Given this list of marker genes PTTG2, C14orf39, TERB2, EHMT2 (euchromatic histone lysine methyltransferase 2), ESPL1, MEIKIN, MND1 (NCBI Gene Id 84057), CENPC, MLH3, MAEL, MLH1, TEX11, MAJIN, CCNB1IP1, SYCE1, SHOC1, SPDYA, RNF212, SPATA22, SYCP2, PTTG1, MSH5, TERF1 (NCBI Gene Id 7013), REC8, MEIOB, HORMAD1, CCNE1, SYCE2, TRIP13, MSH4, DMC1, NDC1, P3H4, SPO11, ZCWPW1 (zinc finger CW-type and PWWP domain containing 1), KNL1, MCMDC2, C9orf78, FANCD2, SYCE1L, PSMC3IP, TERB1, FMN2, ATM, TEX15, SUN1, IHO1, TEX12, AGO4, SIRT7, ANKRD31, ZWINT, STAG3, CCNE2, BRIP1, C1orf146, RNF212B, PRDM9, SYCE3, UBE2B, KASH5, BAG6, MEI4, PLK1, PTTG3P, MRE11, MEIOC, SYCP1, here is a description of the gene set: studied in species Homo sapiens The cell cycle process in which replicated homologous chromosomes are organized and then physically separated and apportioned to two sets during the first division of the meiotic cell cycle. Each replicated chromosome, composed of two sister chromatids, aligns at the cell equator, paired with its homologous partner; this pairing off, referred to as synapsis, permits genetic recombination. One homolog (both sister chromatids) of each morphologic type goes into each of the resulting chromosome sets. Human Gene Set: GOBP_HOMOLOGOUS_CHROMOSOME_SEGREGATION